Given this list of marker genes Lipe, Abhd6, Abhd1, Abhd2, Faah, Mgll, Pnliprp2, Abhd16b, Daglb, Abhd12b, Lipc, Abhd16a, Abhd15 (abhydrolase domain containing 15), Abhd3, Dagla, Abhd12, here is a description of the gene set: Mouse Gene Set: GOMF_MONOACYLGLYCEROL_LIPASE_ACTIVITY Catalysis of the reaction: a monoacylglycerol + H2O = a fatty acid + glycerol + H+. species: Mus musculus